Given this list of marker genes Erc2, Atg7, Ntsr1, Cntnap1, Flrt3, Slc1a6, Th, Rpl29, Stx2, Rpl22, Clta (clathrin light chain A), Glra3, App, Slc6a3, Praf2, Adcy1, Chrm2, Rab3a, Rab6b, P2rx4, Atp6ap2, Chrnb2, Cnga1, Septin7, Stx1a, Grm1, Pcdh17, Tor1a, Atp6v1a, Hnrnpk, Ppp3cc, Mt3, Rps24 (ribosomal protein S24), Dbi, Phb1 (NCBI Gene Id 18673), Rabac1, Cacna1d, Rpl9, Stx6, Rap1a, Ncs1, Cdh2, Pde4b, Senp6, Ap2s1, Slc2a3, Kcna6, Grik3, Baiap3, Slc6a1, Zzef1, Shroom4, Sv2b, Ctnnb1, Kif2c, Ctbp2, Capn2, Gabra3, Ppp1cc, Rpl23, Nptx2, Tanc1, Ddn, Dao, Rpl13a, Slc18a2, Itpr1, Rogdi, Ppt1, Cacnb1, Syt8, Vps18, Wnt7a, Slc6a5, Nefl, Cacna1h, Pak1, Tulp1, Ilk, Kif3c, Dnm2, Stx12, Apc, Unc13a, Cacna1e, Grm4, Btbd8, Adgrl1, Ppfia3 (NCBI Gene Id 76787), Glra1, Nts (NCBI Gene Id 67405), Egflam, Hnrnpab, Sgta, Rab1a, Trappc4, Rpl10a, Rpl6, Trim9, Dlg1, Senp5, Syt7, Nf1, Rpl28, Crhr2, Atp6v1g3, Kcnj6, Tpbg, Gnb5, Snapin, Phf24, Vamp1, Syt4, Hcn1, Kcnab2, Ngfr, Snap47, Rpl4 (NCBI Gene Id 67891), Nrxn1, Ctsd, Rab3gap2, Tnk2, Cd24a, Scamp5, Erbb4, Sema4c (sema domain, immunoglobulin domain (Ig), transmembrane domain (TM) and short cytoplasmic domain, (semaphorin) 4C), Chrna7 (cholinergic receptor, nicotinic, alpha polypeptide 7), Ston2, Esr1, Adra2c, Necab2, Sptbn2, Slc35f1, Pnoc, Prune2, Cntn1, Gabbr1, Ube2m, Slc40a1, Fzd3, Chrna6, Chrna5 (cholinergic receptor, nicotinic, alpha polypeptide 5), Trpm7, Rock2, Vps33b, Slc22a2, Kif1a, Rpl34, Cln3 (CLN3 lysosomal/endosomal transmembrane protein, battenin), Grm3, Atp6v0a4, Calca, Rab40b, Sumo2, Syt12, Kcnip3, Afdn, Atp6v0e2, Calb2, Slc22a3, Snap91, Git1, Sypl1, Fcho2, Clcn3, Sncb, Braf, Ache, Cngb1, Dbh, Lrrk2 (NCBI Gene Id 79409), Cln8, Kcnq5, Napa, Diaph1, Lin7c, Sumo3, Syt10, Rab35, Blvrb, Rps5, Rpl36, Celsr3, Synpr, Ntng2, Syt13, Grin3b, Slc29a4, Rtn4r, Atp2b3, Cyp46a1, Lrfn2, Aph1a, Napepld, Rab13, Psen1, Pi4k2a, Cap1, Slc30a3 (solute carrier family 30 (zinc transporter), member 3), Kctd16, S1pr1, Ap3s2, Canx, Ucn3, Kcnh1, Scn2a, Gpr158, Cacna2d2, Cabp4, Vps45, Cltc, Rab12, Clcn5, Grk3, Sh3glb1, Cd47, Pnisr, Dvl1, Npy, Atp6v0c, Cdh9, Slc6a7, Ano2, Gad2, Vdac1, Rab6a, Chrnb3, Slc22a1, Ap1s1 (adaptor protein complex AP-1, sigma 1), Atp8a1, Mylk2, Psen2, Hcn3, Itga2, Snap25, Calb1, Lamp1, Rps12, Grin3a, Cacna1a (calcium channel, voltage-dependent, P/Q type, alpha 1A subunit), Ap2a1, Bsn, Srcin1 (SRC kinase signaling inhibitor 1), Vps52, Apbb1, Ctnnd1, Slc32a1, Rps27rt, Nos1, Rad51, Ntrk2, Lpar1, Aqp1 (NCBI Gene Id 11826), Scamp1, Atp2b2, Ppp2ca, Dbnl, Syt11, Rabgef1, Efnb3, Rps10, Epha3, Scn1a, S1pr2, Rpl36a, Slc10a4, C1qbp, Ror1, Kcnj8, Rpl7, Grin1, Cdk5r1, Rtn3 (NCBI Gene Id 20168), Gabrb3, Kcnj10, Dnm1, Cltb, Ptpn5, Ptprd (NCBI Gene Id 71786), Asic1, Pip5k1c, Gripap1, Ngf, Snph, Psenen, Scn8a, Mff, Penk, Snx4, Flot1, Pde2a, Stx7, Pias3, Rplp2, Htr7, Cbarp, Mctp2, Prkaca, Ica1, Rps27, Kcnc4, Nmu, Slc6a4, Kcnma1, Fam107a, Cacna1c, Srsf10, Cdh10, Cckar, Snx9, Ube2l3, Ap3d1, Septin5, Cops5, Mal2, Rpl27, Camk2a, Pianp, Adam23, Senp1, Gnrh1, Cplx2, Wdr7, Septin8, Rab5b, Usp5, Ube3a, Arfgef2, Faah, Wfs1, Pick1, Unc13b, Appl1, Nrn1, Slc24a2, Rac1, Septin4, Ctnna2, Best1, Chrna4, Zdhhc17, Syde1, Rpl8 (ribosomal protein L8), Nrxn3, Rps16, Kcnc3, Amph, Prph, Cdh1, Cnrip1, Ap2b1, Cyfip1, Ap2m1, Snca, Got1, Rps27a, Snap29, Rpl35a, Marcksl1, Cplx1, Stxbp1, Ptk2b, Fus, Nlgn1, Septin3, Grm8, Daam1, Scn9a, Apba2, Dmd, P2rx2, Fosl1, Slc2a4, Prkca, Slc17a7, Drd4, Pias1, Svop, Dennd1a, Usp14, Prkcg, Iqsec1, Slc35d3, Cadps2, Rab3b, Ophn1 (oligophrenin 1), Ywhah (tyrosine 3-monooxygenase/tryptophan 5-monooxygenase activation protein, eta polypeptide), Arl6ip5, Hcn4, Unc13c, Slc35g2, Stx19, Grap, Dnajc5, Scgn, Sgip1, Marcks, Itsn1, Gper1, Ppfibp1, Dlg4 (NCBI Gene Id 13385), Slc5a7, Shh, Cd200, Grm7, Sec22b, Mme, Gad1, Opn1sw, Sh3gl3, Gabrb1, Hap1, Tspoap1, Pnmt, Fbxo45 (F-box protein 45), Erc1, Drd2 (dopamine receptor D2), Syn2, L1cam, Cacnb4, Itpr3, P2rx3, Septin6, Stx3, Snx1, Cacna2d3, Atp6v1g2, Disc1, Cad, Slc1a1, Rps26, Slc9b2, Fxyd6, Syt1, Syndig1 (synapse differentiation inducing 1), Nrxn2, Nectin1, Zfp804a, Lingo1, Rab33b, Cxadr, Slc17a6, Syngr1, P2ry4, Grin2b, Senp7, Tmed9, Pfn2, Atp6v1b1, Nlgn2, Mical1, Syt9 (synaptotagmin IX), Slc1a7, Tmem230 (NCBI Gene Id 98764), Anks1b, Npy5r, Syp, Ryk (receptor-like tyrosine kinase), Nptn, Slc18a1, Prrt2, Ndel1, Ephb2, Rpl5, Dnm1l, Kcna2, Rps15a, P2rx1, Slc4a8, Rab26, Grin2a, Cdk16, Tafa4, Grik1, Septin1, Kcna4, Gabra6, Gria2, Prnp, S1pr3, Calm3, Ppfia2, Atp6v1d, Dpysl2, Ap1s2, Rpl24, Gpr151, Dixdc1, Gdi1, Cntnap4, Rpl10, Eps15l1, Ppfia1, Brsk1, Rps6-ps4, Cttnbp2, Atp6v1c1 (NCBI Gene Id 98003), Syn3, Rapgef4, Nufip1 (nuclear FMR1 interacting protein 1), Vti1a, C9orf72, Efr3a, Doc2b, Syngr3, Prkn, Igsf21, Gabra5, Napb, Mpp4, Rnf112, Slc6a11 (solute carrier family 6 (neurotransmitter transporter, GABA), member 11), Rab3d, Scrib, Synj2, Cops4, Calm2, Rpl27a, Lrfn3, Cyp19a1, Gabra2, Vps11, Rps28, Gpm6a, Cacna2d1, Grm2, Actg1, Slc9a6, P2rx7, Atp6v0a1, Kirrel3, Kctd8 (NCBI Gene Id 243043), Rab2a, Epha4, Entpd1, Vdac2, Adra2a (NCBI Gene Id 11551), Vamp3, Syt6, Atp6v1g1, Vamp2, Dtnbp1, Trpc5, Adam10, Syap1, Slc18a3, Apba1, Nos1ap, Atp2b4, Syn1, Htr1a, Shank2, Sncg, Tprg1l, Ppp1ca, Ctbp1, Mettl5, Dlg2, Rimbp2, Cacnb2, Rpl23a, Atp6ap1, Ap1g1, Plekhg5, Nr3c2, Rab5a, Rgs9, Kcnc2, Gabbr2, Npff, Adora2a, Ncstn, Ush2a, Dstn, Lamp5, Arf6, Osbpl2, Anp32e, Rab8a, Lrrc4b, Bdnf, Iqsec2, Dmxl2, Cntn6, Rps11, Rmdn3, Rpl37a, Htt, Cask, Phaf1, Kcnk9, Gabrr1, Sema7a, Pfn1, Dgki, Znrf1, Vti1b, Syngr2, Adora1, Oprm1, Tnik, Kcnj11, Cadm1, Tenm3, Nog, Kcnk2, S1pr4, Hnrnpr, Ston1, P2ry2, Pacsin1 (protein kinase C and casein kinase substrate in neurons 1), Znrf2, Park7, C1qc, Ube2i, Exoc3, Lin7b, Pebp1, Syngr4, Rpl26, Scn11a, Rab3c, Kcna1, Begain, Sypl2, Ddc, Madd, Rpl38, Lin7a, Ap3s1, Stx1b, Grip1 (NCBI Gene Id 74053), Grik5, Pik3c3, Atp1a3, Rab10, Grin2d, Slc8a1, Calm1, Gipc1, Pgr, Rab5c, Kif1b, Ptprs, Ehd1 (EH-domain containing 1), Kcnj9, Gabrb2, Prkcb, Ppfia4, Ogt, Nr4a1, Slc1a2, C1qb, Sri, Pcsk1, Slc17a5, Atr, Cacna1b, Bace1 (NCBI Gene Id 97509), Dnajc6, Pclo, Gria3, Ntf3, Prkce, Htr3a, Myo5a, Fbxl20, Arhgap44, Rapgef3, Doc2a, Git2, Cdk5, Cntnap2, Kcnc1, Smcr8, Grk2, Rpl12, Chrm1, Phb2, Slc17a8, Rpl35, Gria4, Sdcbp, Rab7, Atp6v1b2, Rps14, Rims1, Slc8a3, Tmem163, Otof, Ptprn, Dnm3, Aak1, Sh3gl1, Kctd12b, Syt2, Slc6a17, Tnn, Efnb1, C1qa, Rab4a, Flot2, Kctd12, Cadps, Gap43, Casr, Syt5, Kalrn, Grik2 (NCBI Gene Id 320644), Adora3, Vac14, Rpl7a, Elk1, Ap1b1, Rnf216, Stx16, Necap1, Atm, Atp6v0d1, Slc6a2, Stx11, Adra1a, Fmr1, Pcdh8, Ywhag, Clcn4, Myo6, Cnr1, Atp6v1h (NCBI Gene Id 98576), C1ql1, Gucy1b1, Rab8b, Cplx4, P2ry1, Chrm3, Grik4, Slc8a2, Ntng1, Rims2, Epn1, Rph3a, Mctp1, Slc2a13, Exoc4, Pnkd, Pdlim5, Cdh8, Ccl2, Tbc1d24, Dgkq, Efnb2, Slc6a9, Chrd, Ap3m2, Nrg1, Crhbp, Oprk1, Podxl, Hip1, Cadm3, Hspa8, Dnmbp, Adora2b, Rpl13 (ribosomal protein L13), Vdac3, Atg9a, Ptn, Rpl14, Ano1, Rps6, Rpl37, Arpc2, Lgi3, Thy1, Gpc4, Uba52, Drd1, Adcyap1, Rpl15, Cck, Htr1b, Scn10a, Gnao1, Eea1, Atp6v1e1, Sumo1, Atcay, Erbb2, Rpl32, Itga3, Htr2a, Slc18b1, Adcy8, Vps16, Sh3gl2, Il31ra, Rgs7bp, Mtmr2 (myotubularin related protein 2), Npy1r, Rab11b, Sphk1, Abcc8, Synj1, Crmp1, Ucn, Rab4b, Sv2c, Slc29a1, Slc2a8, Slc4a10, Ntf5, Fkbp1a, Actb, Lpar2, Mgll, Rims3, Vps35 (NCBI Gene Id 65114), Rgs7, Ap2a2, Prss12, Oxt, Rpl17, Arfgap3, Rab27b, Bin1, Ncam1, Cplx3, Rab14, Chrm4, Cntn5, Trio, Adam11, Doc2g, Slc2a1, Ptprn2, Whrn, Rgs10, S1pr5, Rab40c, Bcl2l1, Baiap2, Pdyn, Polg, Prrt1, Scrn1, Atp6v1f, Oprd1, Sv2a, Kcna3, Glul, Kcnj3, Atp2b1, Cyth1, Elfn1, Kif21a, Nefm, Ap3b2, Cdk5r2, Flrt2, Vamp4, Picalm, Rabep1, Gria1, Stx4a, Ppfibp2, Ghrh, Stxbp5, Borcs5, Anxa5, Itsn2, here is a description of the gene set: The part of a synapse that is part of the presynaptic cell. studied in species Mus musculus Mouse Gene Set: GOCC_PRESYNAPSE